The following is a description of a gene set: Genes up-regulated in nsopharyngeal carcinoma relative to the normal tissue. studied in species Homo sapiens from publication Sengupta S, den Boon JA, Chen IH, Newton MA, Dahl DB, Chen M, Cheng YJ, Westra WH, Chen CJ, Hildesheim A, Sugden B, Ahlquist P (PMID 16912175) To identify the molecular mechanisms by which EBV-associated epithelial cancers are maintained, we measured the expression of essentially all human genes and all latent EBV genes in a collection of 31 laser-captured, microdissected nasopharyngeal carcinoma (NPC) tissue samples and 10 normal nasopharyngeal tissues. Global gene expression profiles clearly distinguished tumors from normal healthy epithelium. Expression levels of six viral genes (EBNA1, EBNA2, EBNA3A, EBNA3B, LMP1, and LMP2A) were correlated among themselves and strongly inversely correlated with the expression of a large subset of host genes. Among the human genes whose inhibition was most strongly correlated with increased EBV gene expression were multiple MHC class I HLA genes involved in regulating immune response via antigen presentation. The association between EBV gene expression and inhibition of MHC class I HLA expression implies that antigen display is either directly inhibited by EBV, facilitating immune evasion by tumor cells, and/or that tumor cells with inhibited presentation are selected for their ability to sustain higher levels of EBV to take maximum advantage of EBV oncogene-mediated tumor-promoting actions. Our data clearly reflect such tumor promotion, showing that deregulation of key proteins involved in apoptosis (BCL2-related protein A1 and Fas apoptotic inhibitory molecule), cell cycle checkpoints (AKIP, SCYL1, and NIN), and metastasis (matrix metalloproteinase 1) is closely correlated with the levels of EBV gene expression in NPC. Human Gene Set: SENGUPTA_NASOPHARYNGEAL_CARCINOMA_UP, and this is the list of marker genes: ANKRD46, TNFRSF9, THY1, UHRF1, BRIP1, FN1, RBBP8, NBN, MCM8 (minichromosome maintenance 8 homologous recombination repair factor), DOCK4, GJA1, CHI3L1, DOCK7, HDGFL3 (HDGF like 3), TMEM38B, ITGAV, TM7SF3, RAN, FMNL2, OTUD6B, ECT2, PRRX1, RRM2, TFEC, U2SURP, ZNF260, PAPSS2, RRM1, STAT1, WDHD1, SOCS2, NCAPG, KCNMA1, TTK, BUB1B, MANEA, TNFSF15, DEPDC1B, ACER3, SOCS5, GORAB, ATL2, EZH2, ERAP1, SGO2, DLGAP5, SLC9A7, RAD51AP1, MTF2, CDC7, HNRNPA2B1, PHF20L1, POGLUT1, RBMX, TFRC, MBTD1, PMS1, CDK1, BST2, SCAI, HIVEP1, PTGS2, LINC01094, TTF2, EIF5A2, ZNF431, GMNN, HELLS, LAMB1, XAF1, TIGAR, GATA6, MINPP1, TMPO, FGF2, SLC44A1, PUS7L, CXCL10, MCMBP, PRR11, VASH2, ZNF267, ZNF92, UNG (NCBI Gene Id 7374), PM20D2, VCAN, SOX4, SMC4, FCGR2A, INPP4A, ADAM22, FIGNL1, CTSC, NUP58, TMEM200A, NDC1, CALD1, CAPRIN1, ERO1B (NCBI Gene Id 56605), KLHL5, CD200, DRAM1, KIF11, NUSAP1, DPY19L1, ASCC3, FERMT1, TNFAIP6, CLASP1, SLC39A14, MTR, FRRS1, FAS, SOCS1, KIF18B (NCBI Gene Id 146909), NEDD1, ARNT2, ZNF195, PCNA, TIA1, CEP55, DIAPH3, IL15, IPO5, CCT6A, SCML1, ROBO1, FCGR3B, PBK, ZNF286A, CDH11, DTL (NCBI Gene Id 51514), ACTA2, AGO2, MASTL, PIWIL4, HOXC6, XPO1, SULF1 (NCBI Gene Id 23213), TNFRSF10B, ZNF367, RASSF4, E2F3, NID1, SLC39A6, SSX2IP, SRSF10, MCM4, WDR91, TYMS, SMC1A, VANGL2, FZD7, SLC25A40, DUT, IFNG (NCBI Gene Id 3458), COL1A1, KNL1, CENPK, FLVCR1, PMAIP1, CKAP4, RCN2, CENPJ, IGSF6, PLA2G7, IKBIP, PCLAF, MAD2L1, APOC1, NAP1L1, HAVCR2, DPYSL2, G3BP1, RCN1 (NCBI Gene Id 5954), DUXAP8, ADH5, B4GALT6, COL8A1 (collagen type VIII alpha 1 chain), RACGAP1 (NCBI Gene Id 94651), AKT3, ZNRF3, RBBP9, CD14, HMGB2, QDPR, CHN1, DDX60, RFC3, C11orf96, EFNB2, QSER1, ZGRF1, CHEK1, C6orf141, SPARC, ANLN, FASTKD1, DNAJC9, POLE2, INHBA, ZWINT, ARL6IP6 (NCBI Gene Id 151188), GLS, FBN1, SFXN1, PRC1, ANGPT2, ID2, ARHGAP8, ZNF180, NFKBIA, CBX3, TDG, ERICH1 (glutamate rich 1), PGAP1, ZNF121, LLPH, ERI1, IDH1, ZNF131, NDC80, COL15A1, LAMC1, ESCO2, POSTN, MELK, ANKRD22, TOP2A, DNA2, SLCO5A1, PLAU, COL1A2, COL3A1, FANCI, CDCA7 (NCBI Gene Id 83879), FCGR1A, CSAG3, VEZT (NCBI Gene Id 55591), ATAD2, GALNT11, CXCL9, SRSF3, RBFOX2 (NCBI Gene Id 23543), ADAM23, KITLG, FKBP5, HNRNPLL, MPHOSPH9, GZMB, PARPBP, ADAMTS2, PRNP, PKP4, SYNPO2, OSBPL1A (oxysterol binding protein like 1A), ATP11C, GBP1, COL4A1, COL27A1, STAR, CENPU, CXCL11, ASAP1, GZMH, GAD1, IFIH1, RIF1, LOC102724701, PRKDC, NPNT, ANKRD29, EMILIN2, COL5A2, NFE2L3, CASK, CCNE2, CCL2, GINS1, CENPF (centromere protein F), KIF23, GART, DBF4, NUF2, CCNF, HERC2P9, KIF15, CD274, COL4A2, VRK2, CENPE, TWSG1, CCNA2, HAUS6, NFYB, DSCC1, COL5A1, CEP135, ZNF84, NEMP1, ZBED3, PATL1, GZMA, GNLY